Given this list of marker genes Rps19, Clec7a, Cyba, Slc37a4, Rac2, Apoh, Ncf2, Noxa1, Bcr, S100a9, Ins2, Cybb, Jchain, Grn, Mpo, Slamf8, Ncf1, Insr, Camk1d (calcium/calmodulin-dependent protein kinase ID), Selenok, Prdx2, Trem2, Ncf4, Cybc1, Lipa, Cd24a, Lbp, Slc11a1, Ins1, Dusp10, Rac1, here is a description of the gene set: Mouse Gene Set: GOBP_RESPIRATORY_BURST A phase of elevated metabolic activity, during which oxygen consumption increases; this leads to the production, by an NADH dependent system, of hydrogen peroxide (H2O2), superoxide anions and hydroxyl radicals. studied in species Mus musculus